The following is a description of a gene set: species: Mus musculus Mouse Gene Set: REACTOME_PROTEASOME_ASSEMBLY Proteasome assembly, and this is the list of marker genes: Psma6, Psma2, Psmc4, Psmb2, Psmb10, Psmc5 (NCBI Gene Id 19184), Psmd11, Psmb3, Psmd12, Psma3, Psmd13, Psme1, Psma5, Psmb7, Psmb8, Psme2, Psmd5, Psmd10, Psmg2, Pomp, Psma7, Psmg4, Psmc3 (NCBI Gene Id 19182), Psmb5, Psmd8 (proteasome (prosome, macropain) 26S subunit, non-ATPase, 8), Psmb11, Psmd9, Psmb1, Psmg1, Psme3, Adrm1, Psmg3, Psmd7, Psmd14, Psmd1, Psmd6, Psmb4, Psma1, Psmc2, Psmd4, Psmd2, Psme2b, Psmb6, Psmc6, Psmc1, Psma4, Psmd3